The following is a description of a gene set: Genes containing one or more binding sites for (HSF2) in their promoter regions (TSS -1000,+100 bp) as identified by GTRD version 20.06 ChIP-seq harmonization. species: Homo sapiens from publication Yevshin I, Sharipov R, Kolmykov S, Kondrakhin Y, Kolpakov F (PMID 30445619) Human Gene Set: HSF2_TARGET_GENES, and this is the list of marker genes: TMC1, USP54, COX6C, FLAD1, ATPSCKMT, LENEP, PTPRO, KNTC1, SLEAR, TAF7, CAPRIN1, PLEKHA1, GSTO2, PCBD1, TXNDC15, HSPB9, CERT1, MRPS6, H2BC11, MED27, ENSG00000267698, PSPH, ID3, DARS1, CCND3, NGDN, MATCAP2, PRKD3, DDX41, TP53BP1, SLC1A3, SKIC3, FBXO15, TPT1, RBM23, ENKUR, THAP2, TPR, HSPA1B, SLC35F2, METTL23, USPL1, HSPE1, ELP3, PSMD9, UBE2B, WDPCP, TMEM144 (transmembrane protein 144), H4C13, SH3PXD2A-AS1, MRPL18, IGLV11-55, CEACAM21, HSPA1L, MIR4258, RBM12B-AS1, PPP1R18, STIP1, EXTL3, PAXIP1-AS2, DNAJB4, GTF3C3, MIR5188, MATR3, CCDC121, PHB1, TERF2, LINC02324, SLC5A3, STAT6, CCT8, GPN1, EWSR1 (NCBI Gene Id 2130), CDK3, HSPA4, TEN1-CDK3, ENGASE, STIL, NAALADL2, CHORDC1, NKRF, CRYAB, RBM12B-DT, UBFD1, CXCL9, PWWP3A, TDRD3, BAG3, EPB42, CCT4, SPRY1, GPBP1, SLC44A3, MAP1A, PHTF1, CCT7, SH3BGR, JMJD6, MVB12A, SH3BGRL2, ZNF451-AS1, PMVK, EARS2, LINC00304, NUDC, RBM12B, MRC1, DNAJB6, H2AC11, METTL14-DT, ANAPC16, NXT2, SARAF, HSPD1, UBQLN1, DSE, UPRT, RBM47, RMDN1, DIXDC1, MIR6068, CCT2 (chaperonin containing TCP1 subunit 2), CDC42BPA, CCDC117, CASS4, NR2F2, ST13, GATAD2A, HSPA8, UBQLN1-AS1, UBB, NADK, DAZL, FKBP4, IER5, CKS2, PCNA, KMT2A, FDXACB1, BCL2L11, SRP72, NOP58, HOXA3, PGK1 (phosphoglycerate kinase 1), HSPA6, ZFAND2A-DT, ELOVL5, STAT2, MIB1, CDKL3, TXLNA, CBX3P4, TRA2B, PAQR4, ID2-AS1, FRMD4B, GARNL3, PTGES3, RGS7, PGAM5 (NCBI Gene Id 192111), NUDT9, RGS2, LINC01298, ITGA2, DNAJC16, GAS5, AMMECR1L, BISPR, SNAP23, HSPA1A, TCP1, JOSD1, PNMA8A, ZFAND2A, TSEN15, PLXDC1, FAM3D, SENP1, ASCC1, CCT5, RAB3IP, JUN-DT (JUN divergent transcript), UBC (NCBI Gene Id 7316), HSPB1, TIMM21, RP9P, FTL, OSR2, MICB, MRPL45P2, DUSP3, TPT1-AS1, RAB39A, PLEKHG7, CTDSPL, XPNPEP3, SERINC4, ABCB8, CKS1B (CDC28 protein kinase regulatory subunit 1B), HSPE1-MOB4, MCU, GLO1, CCT6A, H4C8, HSP90AA1, GDF9, HSPH1, HEY2, BST2, ALKBH6, GCNT3, SMAD3-AS1, NKIRAS2, ABHD3, NME1-NME2, ACHE, TTC32, PRMT5-AS1, RANGAP1, MICA, ME1, HMGB1, RIGI, QPCT, IRF2BP1, ABCC2, PLAC8 (NCBI Gene Id 95621), HMG20A, COMMD1, MIR4482, SHC1, PDXK, NME1, CFAP68, PCBP2, TTC32-DT, ERI1, KAT2A, CHD1, HYPK, NUCB1, PEAK1, MBOAT7, ZNF410, MORF4L2, MIR3913-1, CASP4, SPAG1, RNU5D-1